The following is a description of a gene set: Human Gene Set: GOBP_AMPA_SELECTIVE_GLUTAMATE_RECEPTOR_SIGNALING_PATHWAY The series of molecular signals initiated by glutamate binding to an AMPA-selective glutamate receptor on the surface of the target cell, followed by the movement of ions through a channel in the receptor complex, and ending with the regulation of a downstream cellular process, e.g. transcription. species: Homo sapiens, and this is the list of marker genes: SHANK1, NRXN1, MEF2C, ADRB2, NLGN1